Given this list of marker genes RPL18A, ANP32B, RPS14, SRP14, RPS17, ACTG1, RPS12, RPL31, EIF3E, HNRNPK, RPL7, UBB, RPL14, EIF3M, HMGN2, HMGN1, RPL4, FAU, NCL, RPL38 (NCBI Gene Id 6169), RPS25, RPS3, EIF4A1, PSMB1, RPL9 (ribosomal protein L9), RPS9 (NCBI Gene Id 6203), MRPL23, RPS18, UBE2I, RPS28, RPS29, SUMO3, RPL36A, H3-3A, COPS6, RAN, EIF3H, JTB, RPL8 (ribosomal protein L8), ACTB, RPL21, H2AZ2, UBC, SLC25A6, RPS24, YBX1, RPS4X, HSP90AA1, RPL12 (NCBI Gene Id 90679), XRCC6, RPL18, HINT1, RPS3A, RPL15, TUBB, RPLP1, RPS8, GDI2, NACA, CBX3, RPS2, LDHA, DRG1, CFL1, BTF3, RPLP0, EIF4G2, RPLP2, PTMA, YWHAQ, PFN1, SUMO2, RPL22, RPS23, SRSF2, USP22, RPL37, RPL27 (ribosomal protein L27), SNRPB (small nuclear ribonucleoprotein polypeptides B and B1), UBE2L3, PHB2, RPS15A, EEF2 (NCBI Gene Id 408221), RPS19, HNRNPA1, EIF3F, HNRNPC, RPS10, RPL34, CCT2, NONO, RPS11, PABPC1, RPS20, NME2, RPL13A, RPL19 (ribosomal protein L19), DDX49, MAZ (NCBI Gene Id 4150), PCBP2, RPS6, PGK1, ATP5F1A, EEF1B2, NAP1L1, RPL13 (NCBI Gene Id 6137), UQCRH, RPS13, RPL17, RPS27A, EIF4A2, UBA2, NPM1, CCNI, TPT1, EIF3D, RPL35, RPL24, ACP1, HDGF, CCT7, HSP90AB1, OAZ1, RPL29, EEF1D, COX7C, UQCRFS1 (NCBI Gene Id 7386), CLIC1, STRAP, RPL30, GNAS, RACK1, YWHAZ, RPL11, COX4I1, RPL5, RNPS1, SNRPE, HSPD1, ENO1, COX6A1, RPL28, RPL6, ARPC3, RPS7, PPIA (NCBI Gene Id 5478), RPL23, RPL23A, RPS16, PARK7, RPS5, U2AF1, EEF1A1, RPL3, RHOA, TUBA1B, RPS27, RPL32, RPL27A, SLC25A3, RPL10A, EEF1G, here is a description of the gene set: species: Homo sapiens Neighborhood of NPM1 Neighborhood of NPM1 nucleophosmin (nucleolar phosphoprotein B23, numatrin) in the MORF expression compendium Human Gene Set: MORF_NPM1